Given this list of marker genes CD2, PRMT1, LBH, CTCF, TXLNA, JAM3, NFYC, RAN, SLC39A14, ZWILCH, CCL4, ZNF142, PTTG1, TRAC, CREM, DRC3, MFSD13A, CDCA4, SQLE, TESC, DLGAP5 (DLG associated protein 5), PTMA (NCBI Gene Id 91418), TSPYL2, TFDP1, SEPTIN6, MAP7D3, GCH1, CPSF7, ORC1, WNT3, HARS1, CHAF1B, ADAM19, TOX (thymocyte selection associated high mobility group box), SP140, BRD7, PERP, TNFRSF4, RBCK1, IL2RA, HOXB9, PRODH, INAVA, BACH2, MYO5C, LAG3, IFNG, GINS4, PIP5K1A (NCBI Gene Id 8394), RNF144A, SLCO1C1, EAF2, APOBEC3G, MAGOHB (NCBI Gene Id 55110), CEP43, QRSL1, POGLUT2, YOD1 (YOD1 deubiquitinase), PASK, HBEGF, CENPA, CSF2, RPL36AL, SFXN1, MXD1, DNAJC9, HOPX, BIRC5, CLDN1, EIF4G1, TWIST1, POLQ, RAB3A, LDB1, CENPF, NIP7, RTL8A, BCL2, CYLD, UNC45A, FAM110D, BUB1, UBR7, HSPA4L, MORC4, NFKBIA, SRSF4, PIK3CD, PRMT7 (protein arginine methyltransferase 7), RFC1, HMMR, KCNC4, ENY2, CHN1, SF3A1, AGK, DLG3, SNRPD3 (small nuclear ribonucleoprotein D3 polypeptide), HIRIP3, SPC25, THOC5 (NCBI Gene Id 8563), GAD2, ABCC2, SDC4, VAMP1, SMYD3, EXOSC9, ABCA2, CFLAR, CPA3, HMGB3, PINLYP, IL24, PXMP2, STC2, IL18R1, RNASEH2B, ARL4A, PARP1, KLF6, LRRN3, NASP, SYNGR3, SYT11, TPD52, NAMPT, MAP3K7, FASN, SECTM1, RRM1, BEGAIN, SH2D3C, NCBP1, MBIP, RPF1, ABITRAM, GABPB1, MPDU1, ATAD2, PELO, MYB, RPIA, PBK, KIF2C, CMAHP, FKBP14, FUBP1 (NCBI Gene Id 8880), POLD3, PRPF19, FAM117A, GFI1, MLLT11, STIP1, CD244, COX10, DLGAP2, ASB4, HNRNPAB, CHST11, WEE1, POLR2E, PPRC1, DOLPP1, SUPT16H, HSPA2 (NCBI Gene Id 3306), STAG3L1, YLPM1, CCNB2, TYMS, THYN1, CHL1, GLO1, FAM184A, TRMT9B, PPP1R16B, HAS2, NOS2, PMAIP1, CHEK1, HYI, ZEB1, MRPL49, ICOS, AURKA, PGS1, TNF, ANXA3, DNAH6, PDE4D, R3HCC1L, IL32, H2BC11, PMS2P5, FTSJ1, C3orf52, YJU2, VDR, LETM1, LSM4, here is a description of the gene set: studied in species Homo sapiens Genes down-regulated in comparison of dendritic cells (DC) versus Th1 cells. Human Gene Set: GSE3982_DC_VS_TH1_DN from publication Jeffrey KL, Brummer T, Rolph MS, Liu SM, Callejas NA, Grumont RJ, Gillieron C, Mackay F, Grey S, Camps M, Rommel C, Gerondakis SD, Mackay CR (PMID 16474395) In the present study we used Affymetrix oligonucleotide microarrays to produce gene transcription profiles for the major leukocyte types in humans. This comprehensive dataset enabled us to not only establish which genes were expressed in each leukocyte type, but also which genes were expressed in each subset after activation. The used of a comprehensive dataset of gene profiles from all the major human leukocyte subsets enabled a novel and powerful means for identification of genes associated with single leukocyte subsets, or different immune paradigms.